Given this list of marker genes Tmed10, Timm17b, Bcs1l, Pex14, Sec61g, Sec61a1, Timm23, Timm17a, Pex13, Tomm20l, Tomm22, Tomm70a, Bloc1s3, Timm22, Tomm20, Sec61a2, Tomm40, Sec63, Tmed10-ps, Tomm40l, Abca1, here is a description of the gene set: Mouse Gene Set: GOMF_PROTEIN_TRANSMEMBRANE_TRANSPORTER_ACTIVITY studied in species Mus musculus Enables the transfer of a protein from one side of a membrane to the other.